Given this list of marker genes RAB1A, KIF23, LDHC (lactate dehydrogenase C), CFAP46, PFN4, KIF3C, NETO1, CIMIP2C, SPA17, TTLL5, TAC4, EFHB, KIFC3, DNAH1, CFAP298, CFAP65, RAB21, RAB6A, MAP1A, CFAP141, IFT122 (intraflagellar transport 122), LRRC23, AP3B1, KIF7, ODAD2, NEURL1, KIF6, CDR2L (NCBI Gene Id 30850), RUFY3, DNAH17, SORD, CENPE, TSSK4, CELSR2, DNAH7, BBS1, AGBL4 (AGBL carboxypeptidase 4), IFT43, ENKUR, SPAG17, CFAP53, CFAP206, IFT70A, WASF1 (NCBI Gene Id 8936), TRAK2, SLIRP, CFAP161, KIF14, ZMYND12, PCM1 (NCBI Gene Id 5108), KXD1, CFAP221, SMCP, TTLL8, RAB27B, KIF2B, GARIN2, CFAP107, FEZ1, SPEF2, OPA1, AP3S2, CFAP47, MKKS, PGAM4, DNAI3, ATP2B4, ROPN1, DYNC1I1, CFAP43, CCR6, TEKT5, TBC1D21, TSSK6, DNAH6, CFAP68, CFAP95, DAW1, BLOC1S4, DNAAF1, RIBC2, ROPN1L, ATG5, DNAH8 (NCBI Gene Id 90022), CFAP251, IFT52, KIF17, KIF19, KIF12, UXT, DYNC1LI1, SUN2, ODAD1, DNAH2, DNAH14, CFAP44, RNASE10, CFAP70, KIF1C, MREG, BLOC1S2, TERF2, KIF15, NHERF1, BICD2, RIBC1, IFT74, CFAP90, KIF3A, KIF18A, TMEM230, CCDC103, VDAC3, CATSPERE, TEKT3, TLE6, PRSS55, HYDIN, ATG16L1, SLC9B2, TMEM201 (transmembrane protein 201), ROPN1B, BICDL1, INPP5B, KATNB1, CCNYL1 (cyclin Y like 1), PURA, STAU1, KIF5C, DNAH9, VPS13A, CCDC146, HDAC6, KLC4, SPMIP11, POC1B, IFT27, DNHD1, IFT25, KIF22, IFT172, GAS8, EPPIN, IFT70B, CIMIP2A, IQCF1, BORCS5, CFAP73, KIF1A, FSIP2, KIF27, SLC9C1, ARMC2, DYNC1H1, GK2, CFAP61, NME5 (NME/NM23 family member 5), IQUB, SOD1, FYCO1, KIF4B, DUSP21, LCA5, CILK1, SPMIP6, SPAG6, SPEF1, HIF1A, PEX14, DNAH3, BICDL2, DYNC2H1, KIF11, RABGEF1, LRRC46, NPHP3, DNAH5, WDR19, DEFB1, CFAP58, ARL8A, SEMG2, CIMAP1A (NCBI Gene Id 113746), ZMYND10, CCDC38, BICD1, HAP1, DNAI1, YIF1B, HNRNPU, NEFL, HOATZ, TACR1 (tachykinin receptor 1), FUZ, CFAP119, PIERCE1, DDX4, DNAAF4, ATP1A4, GMNC, ACTR10, DLGAP5, RFX3, KLC3, NPHP4, TAC1, IFT22, KIF13B, PIERCE2, KIF5B, SPACA9, RASGRP1, CCDC63, CFAP144, ADAM7, CWH43, CCDC40, CFAP20, KIF13A, DYNLRB1, DYNLT4, IFT56, JHY, SLC22A14, CATSPER4, APC, CLUAP1, TRAF3IP1, DZIP1, APP (NCBI Gene Id 351), CATSPERZ, SNAPIN, DNAH11, RUFY4, AP3S1 (NCBI Gene Id 89412), ACTR3, COPG2, TEKTL1, PGK2, KIF21A, CFAP77, DTNBP1, CLIP3, PLA2G3 (phospholipase A2 group III), WDR35, KIF26B, BBS12, UBB, CDC42, AGTPBP1, CFAP52, IFT140, DYNC2LI1, MAP4, DYNLT5, CFAP45, BBOF1, ARL3, PAFAH1B1, SSX2IP, HSBP1, TACR3, SPAST, DRC1, NEFH, BORCS7, MAPK8IP3, DNAH10, TEKT2, EFHC2, DRC7, SEMG1, CABS1, ACTR2, STK11, KIF25 (NCBI Gene Id 3834), SPMIP10, DLG2, TUBB4B, TTLL6, PLTP (phospholipid transfer protein), TMEM108, SAXO4 (NCBI Gene Id 220004), KIF20B, SFPQ, CABYR, AP3D1, AP3M2, KIFC2, CFAP276, TCTE1, FMN2, AP3M1, CYB5D1, DNAI4, MAP2K1, INTS13, NEK10, SUN1, SPMIP9, CELF3, BORCS8, KIAA0319L, DYNC1LI2 (dynein cytoplasmic 1 light intermediate chain 2), SEPTIN4, ING2, SPG11, C2CD6, TMF1, TACR2, GARIN3, KIFBP, TEKT1, IFT46 (intraflagellar transport 46), CCDC88C, LCA5L, TMEM232, ASH1L, DNAAF5 (dynein axonemal assembly factor 5), ARHGAP21, CFAP54, TEKT4, TEX101, SPAG16, MGARP, QRICH2, NDEL1, STARD7, DYNLT2, MAP1S, SYBU, CAMSAP3, SLC9B1, STAU2, CFAP157, SLC22A16, KIF1B, APBA1, NDE1, TAC3, GAPDHS, BORCS6, CEP131, KIF5A, SPEM3, DNAI2, DNAH12, TPGS1, CFAP210, STK36, LZTFL1, KPNB1, IFT20, IFT80, AKAP4, RABL2B, IRGC, CFAP97D1, SPMIP8, RHOT2, TPPP2, CCDC39, EFHC1, AKAP3, MAP1B, LRPPRC, DNAL4, AQP4, DNAAF3, FBXW11, IGBP1, FLOT2, CATSPER2 (cation channel sperm associated 2), DYNLRB2, NME8, ODAD4, SPG7, KLC1, TTC12, CFAP69, DYNLT2B, TRIM46, GAS2L2, BBS4, SPEM1, ARMC12, VANGL1, TTLL1, SSNA1, KIF9, KTN1, KIF28P, INTU, ARL8B, TTC21B, DST, HTT, KIF4A, DNAAF2, SPAG8 (sperm associated antigen 8), SYNE2, IQCG, ARMC3, KIF2A, DYNC1I2, BLOC1S1, KIF21B, DYNLT3, TRIM58, KIF2C, TTLL3, DNAAF11, FNTA, APOB, KATNIP, CCDC65, DYNLL1, AP3B2, CLN3, BBS2, COPG1, EFCAB9, CFAP126, KIFC1, PACRG, RSPH6A, TNP1, TTLL9, KIFAP3, KIF3B, DNALI1, DCTN1, WDPCP, BLOC1S3, RHOT1, MNS1 (NCBI Gene Id 55329), KIF20A, RSPH4A, UCHL1, IFT57, KIF24, UBE2B, TTC29, ADCY3, TRAK1, CFAP91, KIF16B, IFT81, KIF18B, TUBA1A, MAPT, DNAAF6, CFAP100, OFD1, KLC2, STARD9, MEIG1, CATSPER1 (NCBI Gene Id 117144), ADCY10, DYNLT1, CCDC159, MAP2, HSPB1, NME7, FNTB (NCBI Gene Id 2342), CATSPER3, CLXN, CEP128 (NCBI Gene Id 283580), PRDM14, ARMCX3, MAFIP, RPGR, PDCL2, EFCAB6, MAK, TTC21A, ODAD3, IFT88, CFAP57, CATSPERD, LAMP1, TUB, BAG3, DPCD, RAB17, PRM3, DYNC2I1, TEKTIP1, BLOC1S6, RSPH9, CEP78, DYNC2I2, BLOC1S5, KIF26A, here is a description of the gene set: A microtubule-based process that results in the movement of organelles, other microtubules, or other cellular components. Examples include motor-driven movement along microtubules and movement driven by polymerization or depolymerization of microtubules. species: Homo sapiens Human Gene Set: GOBP_MICROTUBULE_BASED_MOVEMENT